The following is a description of a gene set: Mouse Gene Set: GOCC_ELONGATOR_HOLOENZYME_COMPLEX species: Mus musculus A heterohexameric protein complex composed two discrete heterotrimeric subcomplexes that is involved in modification of wobble nucleosides in tRNA., and this is the list of marker genes: Elp2, Elp3, Elp6, Elp4, Elp5, Elp1